The following is a description of a gene set: studied in species Homo sapiens Small hands and feet in proportion to the rest of the body. Acromicria Human Gene Set: HP_ACROMICRIA, and this is the list of marker genes: SNORD115-1, PWRN1, MEG3, MAGEL2, SLC26A2, SNORD116-1, PWAR1, MKRN3, GH1, RTL1, HERC2, DLK1, NPAP1